Given this list of marker genes Cfap68, Efhb, Tekt2, Tektip1, Tekt5, Cfap53, Spmip5, Nme7, Ribc1 (RIB43A domain with coiled-coils 1), Efcab6, Cfap107, Spmip6, Cfap161, Spmip11, Tekt4, Tekt1 (NCBI Gene Id 21689), Spmip9 (sperm microtubule inner protein 9), Cfap141, Efhc2, Pierce1, Ribc2, Cimip2c, Spmip8, Efhc1, Cimip2b, Tekt3, Dusp21, Saxo4, Pierce2, Mns1, Cimip2a, Spag8, Cfap95, here is a description of the gene set: A structural network of microtubule inner proteins (MIPs) located inside the lumen of the A tubule of the axonemal microtubule doublet that helps stabilize the A tubule. studied in species Mus musculus Mouse Gene Set: GOCC_AXONEMAL_A_TUBULE_INNER_SHEATH